Given this list of marker genes WNT7A, RNU4ATAC, CCN2, SOST, LRRK1, FIG4, COL11A1, GLI3, LEMD2, NAA10, PCNT, MBD5, IFT140, DYNC2I1, PORCN, RBM8A, TWIST1, CDT1, FRG1, B4GALT7, HPGD, CDC42BPB, LBR, FGFR1, AMER1, TBX5, FBXL3, ATP7A, DYNC2LI1, GJA1, CDC6, MEG3, HHAT, CSPP1, BANF1, DNMT3B, MMP2, ALX4, IFT81, SLC35D1, EYA1, TBX3, DYNLT2B, CBFB, MSX2, SKI, DUX4L1, PTH1R, LMNA, FKBP10, TBCE (tubulin folding cofactor E), SRCAP, CHD4 (chromodomain helicase DNA binding protein 4), WNT3, PTDSS1, BGN, SETBP1, FLNA, SALL4, FGFR3, FLNB, SCARF2, PTEN, WDR19, KIAA0586, TTC21B, DYNC2I2, IFT172, SH3PXD2B, KIF7, VAC14, RTL1, TBX15, RUNX2, FGFR2, DCHS1, RNU12, INTU, ORC4, HOXD13, EFNB1, CTSK, ZMPSTE24, RSPO2, FAT4, ANTXR1, LRP5, IFT80, BCOR, CEP120, TNFRSF11B, IDUA, TRPV4, CHRNG, SMCHD1, XYLT1, BMPR1A, CDC45, DUX4, NEK1, INPPL1 (NCBI Gene Id 3636), KIAA0753, NSDHL, ARSK, PAX1, DLK1, COL1A1, ORC1, ORC6 (NCBI Gene Id 23594), MYSM1, DYNC2H1, PIGL, MMP14, GMNN, TNFRSF11A, TRIP11, SLC26A2, here is a description of the gene set: Human Gene Set: HP_ABNORMAL_CLAVICLE_MORPHOLOGY Any abnormality of the clavicles (collar bones). studied in species Homo sapiens Abnormal clavicle morphology